The following is a description of a gene set: part of: Interleukin-1 signaling; MAP kinase activation studied in species Homo sapiens Tumor progression locus-2 (TPL2, also known as COT and MAP3K8) functions as a mitogen-activated protein kinase (MAPK) kinase kinase (MAP3K) in various stress-responsive signaling cascades. MAP3K8 (TPL2) mediates phosphorylation of MAP2Ks (MEK1/2) which in turn phosphorylate MAPK (ERK1/2) (Gantke T et al., 2011).<p>In the absence of extra-cellular signals, cytosolic MAP3K8 (TPL2) is held inactive in the complex with ABIN2 (TNIP2) and NFkB p105 (NFKB1) (Beinke S et al., 2003; Waterfield MR et al., 2003; Lang V et al., 2004). This interaction stabilizes MAP3K8 (TPL2) but also prevents MAP3K8 and NFkB from activating their downstream signaling cascades by inhibiting the kinase activity of MAP3K8 and the proteolysis of NFkB precursor protein p105. Upon activation of MAP3K8 by various stimuli (such as LPS, TNF-alpha, and IL-1 beta), IKBKB phosphorylates NFkB p105 (NFKB1) at Ser927 and Ser932, which trigger p105 proteasomal degradation and releases MAP3K8 from the complex (Beinke S et al., 2003, 2004; Roget K et al., 2012). Simultaneously, MAP3K8 is activated by auto- and/or transphosphorylation (Gantke T et al. 2011; Yang HT et al. 2012). The released active MAP3K8 phosphorylates its substrates, MAP2Ks. The free MAP3K8, however, is also unstable and is targeted for proteasome-mediated degradation, thus restricting prolonged activation of MAP3K8 (TPL2) and its downstream signaling pathways (Waterfield MR et al. 2003; Cho J et al., 2005). Furthermore, partially degraded NFkB p105 (NFKB1) into p50 can dimerize with other NFkB family members to regulate the transcription of target genes.<p>MAP3K8 activity is thought to regulate the dynamics of transcription factors that control an expression of diverse genes involved in growth, differentiation, and inflammation. Suppressing the MAP3K8 kinase activity with selective inhibitors, such as C8-chloronaphthyridine-3-carbonitrile, caused a significant reduction in TNFalpha production in LPS- and IL-1beta-induced both primary human monocytes and human blood (Hall JP et al. 2007). Similar results have been reported for mouse LPS-stimulated RAW264.7 cells (Hirata K et al. 2010). Moreover, LPS-stimulated macrophages derived from Map3k8 knockout mice secreted lower levels of pro-inflammatory cytokines such as TNFalpha, Cox2, Pge2 and CXCL1 (Dumitru CD et al. 2000; Eliopoulos AG et al. 2002). Additionally, bone marrow-derived dendritic cells (BMDCs) and macrophages from Map3k8 knockout mice showed significantly lower expression of IL-1beta in response to LPS, poly IC and LPS/MDP. However, several other studies seem to contradict these findings and Map3k8 deficiency in mice has been also reported to enhance pro-inflammatory profiles. Map3k8 deficiency in LPS-stimulated macrophages was associated with an increase in nitric oxide synthase 2 (NOS2) expression. Similarly, expression of IRAK-M, whose function is to compete with IL-1R-associated kinase (IRAK) family of kinases, was decreased in Map3k8-/- macrophages while levels of TNF and IL6 were elevated. Moreover, significantly higher inflammation level was observed in 12-O-tetradecanoylphorbol-13-acetate (TPA)-treated Map3k8-/- mouse skin compared to WT skin (DeCicco-Skinner K. et al., 2011). Additionally, MAP3K8 activity is associated with NFkB inflammatory pathway. High levels of active p65 NFkB were observed in the nucleus of Map3k8 -/- mouse keratinocytes that dramatically increased within 15-30 minutes of TPA treatment. Similarly, increased p65 NFkB was observed in Map3k8-deficient BMDC both basally and after stimulation with LPS when compared to wild type controls. The data opposes the findings that Map3k8-deficient mouse embryo fibroblasts and human Jurkat T cells with kinase domain-deficient protein have a reduction in NFkB activation but only when certain stimuli are administered. Thus, it is possible that whether MAP3K8 serves more of a pro-inflammatory or anti-inflammatory role may depend on cell- or tissue type and on stimuli (LPS vs. TPA, etc.).<p>MAP3K8 has been also studied in the context of carcinogenesis, however the physiological role of MAP3K8 in the etiology of human cancers is also convoluted (Vougioukalaki M et al., 2011; DeCicco-Skinner K. et al., 2012). Reactome Pathway: MAP3K8 (TPL2)-dependent MAPK1/3 activation, and this is the list of marker genes: CUL1, SKP1, TNIP2, BTRC, UBB, UBA52, FBXW11, MAP3K8, MAP2K1, RPS27A, IKBKG, MAP2K4, NFKB1, IKBKB, CHUK, UBC